The following is a description of a gene set: Any nuclear DNA replication that is involved in a mitotic cell cycle. species: Mus musculus Mouse Gene Set: GOBP_MITOTIC_DNA_REPLICATION, and this is the list of marker genes: Rad51, Cdc45, Mcm2, Lig1, Pola1, Zmpste24, Fgfr1, Gins3, Gins1, Brca2, Mcm4, Mcm3, Rtf2, Recql5, Tk1, Mcm6